The following is a description of a gene set: Mouse Gene Set: REACTOME_TRANSPORT_TO_THE_GOLGI_AND_SUBSEQUENT_MODIFICATION Transport to the Golgi and subsequent modification species: Mus musculus, and this is the list of marker genes: Mgat2, Spta1, Ctsc, Golga2, Gbf1, Ins1, Ankrd28 (NCBI Gene Id 218881), Tgfa, Scfd1, Kdelr3, Stx5a, Mgat1, Mgat4b, Dctn2, St3gal4, Capzb, Trappc10, Ykt6, Folr1, Tmed9, Dctn4, Stx17, Dctn1, Fuca1, Trappc1, Arfgap1, Tubal3, Trappc4, Rab1b, F5, Dync1h1, Tmed10, Copa, Arf1, Cog6, Sptbn5, Tuba1a, St8sia6, Sptbn2, B4galt5, Cnih1 (NCBI Gene Id 218969, cornichon family AMPA receptor auxiliary protein 1), Col7a1, Trappc2l, Kdelr2, Sec24a, Sptan1, Cog1, Tmem115, Ank1, Tmed2 (NCBI Gene Id 76322), Napb, Capza2, Lman1, St8sia3, B4galt3, B4galt6, Lman2, Ppp6r1, Tuba3a, Dctn5, Cd59b, Man1a, Cog4, Chst10 (carbohydrate sulfotransferase 10), Man2a2, St6gal1 (beta galactoside alpha 2,6 sialyltransferase 1), Copb2, Tuba8, Tubb2b, Tuba4a, Trappc6a (NCBI Gene Id 75105), Bet1l, Tuba1c, Fut8, Cog5, Ctsz, Sec16b, Copz1, Actr10, Sec24b, Dynll1 (NCBI Gene Id 56455), Lman1l, Golgb1, B4galt2 (UDP-Gal:betaGlcNAc beta 1,4- galactosyltransferase, polypeptide 2), Mia3, Copz2, St8sia2, Sec23ip, Tubb6, Tbc1d20, Sec24c, Sar1b, Ppp6c, Gosr1, Chst8, Tubb3, Cope, Gria1, Trappc3, F8, Arfgap3, Tubb4b, Cnih2, Areg, Trappc9, Dynll2, Trappc6b, Mgat3, Sec23a, Tmed3, Mgat5, Arf5, Gorasp1, Mgat4c, Rab1a, Copg1, Sec24d, Sec31b, Copb1, Dync1i2, Sptbn4, B4galt1, Tfg, Copg2, Sec13, Napa, Tuba3b, Arf4, Dctn3, Dctn6, Mia2, Sec22a, Man2a1, Nsf, Dync1li1, Actr1a, Cnih3, Uso1, Lhb, Capza3, Man1a2, Mcfd2, B4galt4, Cga, Man1c1, Tubb4a, Bet1, Trappc5, Sec22c, Mgat4a, Dync1li2 (NCBI Gene Id 234663), Arf3, Tmed7, Cog2 (NCBI Gene Id 97472), Ppp6r3, Cog8, Lman2l, Sptbn1 (spectrin beta, non-erythrocytic 1), Sec16a, Arcn1, Preb, Dync1i1, Csnk1d, Kdelr1, Tubb2a, Trappc2, Tuba1b, Arfgap2, Sec22b, Serpina1b, Sec31a, Cog3, Cog7, Manea, Serpina1c, Tubb1, Napg, Sptb, Cd55, Gosr2